The following is a description of a gene set: Senescence and autophagy in cancer Human Gene Set: WP_SENESCENCE_AND_AUTOPHAGY_IN_CANCER studied in species Homo sapiens, and this is the list of marker genes: IRF7, ATG16L1, ATG14, IGF1, SQSTM1, IGF1R, GABARAP, TP53, MTOR, ING2, IL24, TGFB1, RAF1, CCL3, SH3GLB1, BCL2, GSK3B, BMP2, CXCL14 (NCBI Gene Id 9547), ATG12 (NCBI Gene Id 9140), ATG13, BECN1, CDKN2A, MDM2, JUN, IL6, SMAD4, COL10A1, CDKN1A, GSN, AMBRA1, SERPINE1, MAPK1, KMT2A, MAP2K1, SLC39A3, IL1A, SLC39A2, IFNB1, PLAU, HMGA1, LAMP1, CD44, CDKN1B, PCNA, SLC39A1, BMI1, MMP14, MAPK14, HRAS, E2F1, COL3A1, TNFSF15, ATG10, IL1B, ATG7, SRC (SRC proto-oncogene, non-receptor tyrosine kinase), MAP1LC3A, CDC25B, MLST8, IL6ST, IRF1, COL1A1, PIK3C3, ING1, SMAD3, IGFBP7, RSL1D1, CXCL8 (NCBI Gene Id 3576), PLAT, FN1, IFI16 (NCBI Gene Id 3428), CEBPB, RB1, GABARAPL1, INHBA (NCBI Gene Id 3624, inhibin subunit beta A), RB1CC1, AKT1S1, MAP1LC3B, LAMP2, SPARC (secreted protein acidic and cysteine rich), CREG1, VTN, ATG3, ATG5, UVRAG, MAP1LC3C, IGFBP5, MAP2K3, GABARAPL2, IL6R, SERPINB2, SLC39A4, BRAF, FKBP8, ULK1, IGFBP3, THBS1, RNASEL, IFNG, IRF5, INS, CXCL1, IL3, PTEN